Given this list of marker genes IFT172, BBS2, LIPC, ERCC6, PMM2, HYMAI, PTPN1, PCYT1A (NCBI Gene Id 5130), LEMD2, PIK3R1, BBS1 (NCBI Gene Id 79702), CIDEC, BSCL2, HNF4A, LIPE, PLAGL1, IGF2BP2, WDPCP, MAPK8IP1, GPR101, ALMS1, KLF11, NSMCE2, BBS4, CEP19, GCK, DBH, BBS12, IRS2, SCAPER, POLD1, BLK, HNF1B, BBS9, TTC8, IFT74, PDX1, IGF1, ABCC8, GATA6, IRF4, LMNB2 (NCBI Gene Id 84823), HSD11B1, PHLDB1, CAVIN1, BBIP1, XRCC4, LMNA, NEUROD1, HNF1A, BBS7, ENPP1, TCF7L2, CFAP418, PLAAT3, KCNJ11, SDCCAG8, WFS1, CAV1, IRS1, STAT3, PLIN1, HMGA1, PTF1A, AKT2, PAX4, ZMPSTE24, LZTFL1, MICU1, FOS, SLC30A8, MKS1, CYP19A1, GPD2, PPARG, CEL, CEP290, MTNR1B, SLC2A2, NPHP1, CCDC28B, ADCY3, PPP1R3A (NCBI Gene Id 5506), GRB10, ZFP57, CLCNKB, MKKS, LEP, SCLT1, EIF2AK3, TRIM32, INSR, WRN, SLC5A2, ARL6, INS, IGFALS, AIP, LEPR, CNOT1 (NCBI Gene Id 51579), BBS10, RETN, MFN2, BLM, IFT27, BBS5, SLC12A3, AGPAT2, IL6, APPL1, here is a description of the gene set: Human Gene Set: HP_INSULIN_RESISTANCE species: Homo sapiens Increased resistance towards insulin, that is, diminished effectiveness of insulin in reducing blood glucose levels. Insulin resistance